Given this list of marker genes NFKB1 (NCBI Gene Id 4790), NFKB2, MYD88, DHX9, RELA, DHX36, IRF7, here is a description of the gene set: species: Homo sapiens Human Gene Set: REACTOME_DEX_H_BOX_HELICASES_ACTIVATE_TYPE_I_IFN_AND_INFLAMMATORY_CYTOKINES_PRODUCTION DEx/H-box helicases activate type I IFN and inflammatory cytokines production